The following is a description of a gene set: The pleiotropic activities of interferons (IFNs) are mediated primarily through the transcriptional regulation of many downstream effector genes. The mRNA profiles from IFN-alpha, -beta, or -gamma treatments of the human fibrosarcoma cell line, HT1080, were determined by using oligonucleotide arrays with probe sets corresponding to more than 6,800 human genes. Among these were transcripts for known IFN-stimulated genes (ISGs), the expression of which were consistent with previous studies in which the particular ISG was characterized as responsive to either Type I (alpha, beta) or Type II (gamma) IFNs, or both. Importantly, many novel IFN-stimulated genes were identified that were diverse in their known biological functions. For instance, several novel ISGs were identified that are implicated in apoptosis (including RAP46/Bag-1, phospholipid scramblase, and hypoxia inducible factor-1alpha). Furthermore, several IFN-repressed genes also were identified. These results demonstrate the usefulness of oligonucleotide arrays in monitoring mammalian gene expression on a broad and unprecedented scale. In particular, these findings provide insights into the basic mechanisms of IFN actions and ultimately may contribute to better therapeutic uses for IFNs. species: Homo sapiens from publication Der SD, Zhou A, Williams BR, Silverman RH (PMID 9861020) Human Gene Set: DER_IFN_ALPHA_RESPONSE_DN Genes down-regulated in HT1080 cells (fibrosarcoma) by treatment with interferon alpha for 6 h., and this is the list of marker genes: EIF3E, PLPP3 (phospholipid phosphatase 3), FBXW4P1, FEZ1, LARP4B, COX17